Given this list of marker genes Sec24c, Ugt1a6a, Spred1, Impg1, Zfp367 (zinc finger protein 367), Ugt1a10, Ugt1a2, Ccnc, Ist1 (NCBI Gene Id 71955), Tnc, Ugt1a5, Cep120, Onecut2, Msh4, Cd200r1, Ugt1a1, Ugt1a7c (UDP glucuronosyltransferase 1 family, polypeptide A7C), Zbtb6, Wapl, Spock1, Kmt2c (lysine (K)-specific methyltransferase 2C), Vcpip1, Api5, Csnk1g1, Aldh18a1, Mastl, Mob4, Ccne2, Hnf4g, Cd200r2 (Cd200 receptor 2), Mtx3, Rasl10a, Brip1, Miga1, Ube3a (NCBI Gene Id 76097), Ap1g1, Zfand6, Ugt1a9, Snrnp48, Ephb4, Vmn2r89, Reps2, Atosa, Rc3h2, Krtap4-7, Ube2n, Fbxw2, Vapa, Gabrp, Nebl, Kpna3 (karyopherin subunit alpha 3), Cbl, Ubxn2b, Slc25a17, Kcnt2, Flvcr2, Gabra2, Spink2, G3bp1, here is a description of the gene set: species: Mus musculus Mouse Gene Set: MIR_3086_3P from publication Chen Y, Wang X (PMID 31504780) Genes predicted to be targets of miRBase v22 microRNA mmu_miR_3086_3p in miRDB v6.0 with MirTarget v4 prediction scores > 80 (high confidence targets).